Given this list of marker genes ACE2, SLC7A5, PSEN1 (NCBI Gene Id 5663), AVP, GABBR1, RAB3GAP1, SLC12A2, STXBP1, ADORA2A, DTNBP1, SLC17A8, P2RX7, SYT4, CLTRN, ABAT, AVPR1A (NCBI Gene Id 552), TRH, NTSR1, KMO, SLC38A3, ARL6IP1, ITGB1, here is a description of the gene set: Human Gene Set: GOBP_POSITIVE_REGULATION_OF_AMINO_ACID_TRANSPORT Any process that activates, maintains or increases the frequency, rate or extent of the directed movement of amino acids into, out of or within a cell, or between cells, by means of some agent such as a transporter or pore. species: Homo sapiens